Given this list of marker genes AGAP3, NSG2, CBLB, DLG3, SHROOM4, GRIP1, GHSR, TRAF6, PORCN, RAB8A, CNIH3, SUSD4, VPS26B, NETO1, SYT17, GRIP2, RALA, AP2M1, DRD4, SHISA6, GRID2IP, ITGB3, TFRC, ALS2, GIT1, LPAR1, RNF220, CPT1C, STX4, CACNA2D2, OGT, NCDN (neurochondrin), HIP1, ATG5, C1QL3, CALY (calcyon neuron specific vesicular protein), CTNND1, SNX6, RABEP1, RAPSN, TAMALIN, SST, GPHN, HRAS, CPLX1, CACNG7, MAP2K1, FLOT2, DLG1, CACNG4, OLFM1, USP46, AP2A2, HSP90AA1, NSG1, LHFPL4, ERBB2, GSG1L, MDM2, ERBIN, LRRC7, ARC, PRKCI, NUMB, CLSTN1, AP2B1, EFNB2, EPS8, CACNG3, GRIPAP1, ZDHHC2, NETO2, AP2S1, USP6, SCRIB, PPP3R1, GPSM2, FRRS1L, EPS15, ATAD1, SLC12A5, NPTX1, SACM1L, ADAM10, GPC4 (NCBI Gene Id 2239), VWC2, GRID1, STX3, OPHN1, SNX27, IQSEC2, ERBB4, HPCA, RDX, CACNG2, GRID2, RAB11A, NRG1, CACNG8, DAG1, PRKN, CACNG5, AP3M1, GPC6, TMEM108, AP2A1, LGI1, RAP2A, VAMP4, RAP1A, C1QL2 (complement C1q like 2), EPB41L3, ARHGAP44, PPFIA1, VAC14, GABARAP (GABA type A receptor-associated protein), KIF2C, ZDHHC5 (NCBI Gene Id 25921), DLG4, DLG2, VPS35, here is a description of the gene set: Any process that regulates the the local concentration of neurotransmitter receptor at the postsynaptic membrane. Human Gene Set: GOBP_REGULATION_OF_POSTSYNAPTIC_MEMBRANE_NEUROTRANSMITTER_RECEPTOR_LEVELS species: Homo sapiens